The following is a description of a gene set: Human Gene Set: REACTOME_BETA_CATENIN_INDEPENDENT_WNT_SIGNALING species: Homo sapiens Beta-catenin independent WNT signaling, and this is the list of marker genes: AP2A1, PDE6G, DVL2, ITPR3, AGO4, FZD7, CLTB, NFATC1, UBB, WNT5B, PSMD1, PSMA2, RHOA, GNB4 (G protein subunit beta 4), PSMD6, FZD3, VANGL2, TNRC6C, PSMA6, FZD4, GNB5, PSMD12, GNG11, PRKG2, PRKCA, PDE6B, GNG10, PSMA5, RAC3, PSMC2, UBC, GNAO1, PPP3CB (NCBI Gene Id 5532), GNG13, PSMB1, UBA52, FZD8, GNAT2, PARD6A, PSMC4, AGO1, PSMA4, GNG8, NLK, CALM1, AGO2, GNGT1 (G protein subunit gamma transducin 1), CAMK2A, PSMB2, LEF1, DAAM1, RAC1, DVL3, DVL1, SCRIB, ITPR1, SEM1, RAC2, PFN1, PSMC5, TNRC6A, PSMD11, PSMA1, GNB3, PRKCG, ADRM1, GNG2, PSMD13, PLCB3, GNGT2, TCF7L2, AXIN2, ROR2, PSMA7, GNG4, PSMB5, MOV10, WNT4, KRAS, PRKG1, TCF7L1, GNG3, FZD5, SMURF1, WNT1, SMURF2, AP2A2, PSMD7, FZD1, PSMC3, RPS27A, TNRC6B, PSMD2, ARRB2, PSMD3, PDE6A, PLCB1, RYK, PPP3R1, GNG5, GNB1, PSMD14, PSMC6, FZD6, PSMC1, PSMB6, PRKCB (protein kinase C beta), MYC, MAP3K7, AP2M1, WNT5A, PSMA3, ROR1, PSMB4, PSMD8, GNG12, WNT11, PPP3CA, AP2S1 (adaptor related protein complex 2 subunit sigma 1), GNB2, AP2B1, AGO3 (NCBI Gene Id 79910), GNG7, FZD2 (frizzled class receptor 2), CLTC, PLCB2, CLTA, PSMB3, ITPR2, TCF7, PSMB7, CTNNB1, PRICKLE1